Given this list of marker genes DMAP1, KCTD6, DENND6B, COQ10A, ZNF627, TANC1, LGALS9B, ANKRD13B, ESM1, IFT74, DLX2, RBMS2, KDM5B, TRMT1L (tRNA methyltransferase 1 like), CFAP97, NAB2 (NGFI-A binding protein 2), MAPRE3, LPP, BMI1, TUBB2A, SSH2, ATP8A1, CCS, BCKDHA, P2RX4, SPSB1, IFIT3, RIGI, C3orf33, PTGFRN, AHI1, FARSB, DNAH8, ARHGAP25, TP53INP1, SPOUT1, RREB1, CCDC126, LSM12, TNIP1, ATRAID, XAF1, IMMP2L, TNFSF11, RBM22, VCP, UBE3A, RING1, TNFSF8, ZCCHC12, MIGA1 (NCBI Gene Id 374986), DLG3, CUL9, ARHGAP39, PGS1, MARCKSL1, TESC, SCARNA13, HEXIM1, FAM168A, HIVEP2, RAC3, TFPI, RHOH, RPL30, SLC9A9, C19orf12, RCL1, CEP43, ARHGAP5, UBA7, C12orf57, COQ8A, GATAD2B, TRPM1, SCNM1, IFIT1B, LDOC1, CELA3B, RNF146, CYP4V2, CRPPA, LUZP1, PHF21A, CSTB, SLC46A3, GGPS1, PARP9, MANBAL, CSN3, GRHL1, TBC1D4, MFSD9, AGL, KSR1, GADD45B, WDFY2, OLFM2, MGST2, ZNF48, UBL5, PTPRE, PFKM, CLIP3, WDR43 (WD repeat domain 43), AICDA, GPAM, NTPCR, FAM120B, NRSN1, EXT1, CERS6, PNPO (pyridoxamine 5'-phosphate oxidase), LKAAEAR1, LIF, ANGPTL2, C19orf38, NPY4R, GTDC1, RASSF2, TOX2, TDRP, ADCK5, VCPIP1, D2HGDH, ATG10, RWDD3, AP3M2, SLC14A1, MX1, ZBTB4, LRIG1, TOR3A, EVI5, ZNF697, RSPH9, NARF, MATK (megakaryocyte-associated tyrosine kinase), ANKMY2, TRPC4AP (transient receptor potential cation channel subfamily C member 4 associated protein), DYNLT3, CHIA, CYTH3, AFP, LGR4, OAS2, ACP6, DYNLT2B, SMYD3, SUCLG1, CMC1, MPO, UTRN, DIS3L2, PTPN13, WNK3, ARID1B, FUNDC1, SLC30A8, MBNL2, CPN2, CCDC171, THNSL1, C8orf48, PHACTR2, NXPE3, SPOCK2, STX4 (NCBI Gene Id 6810), SLC46A1, SYNJ2, RPL19, RBM45, HEXA, LRRC28, EI24, TMEM86A, ITPR2, POLG, HSBP1, KIAA1549L, COLCA1 (colorectal cancer associated 1), CCDC28A, UBAC2, ADK, L3MBTL3, MRPL23, MAPK11, FAM171B, ZFP1, RYR1, DUSP6, DRC1, SLC26A2, LMNTD2, ABTB1, MRTFB, FLVCR2, ZNF878, SYT11, TSPAN32, here is a description of the gene set: Regulatory T (Treg) cells, whose identity and function are defined by the transcription factor Foxp3, are indispensable for immune homeostasis. It is unclear whether Foxp3 exerts its Treg lineage specification function through active modification of the chromatin landscape and establishment of new enhancers or by exploiting a pre-existing enhancer landscape. Analysis of the chromatin accessibility of Foxp3-bound enhancers in Treg and Foxp3-negative T cells showed that Foxp3 was bound overwhelmingly to pre-accessible enhancers occupied by its cofactors in precursor cells or a structurally related predecessor. Furthermore, the bulk of Foxp3-bound Treg cell enhancers inaccessible in Foxp3- CD4+ cells became accessible upon T cell receptor activation prior to Foxp3 expression with only a small subset associated with several functionally important genes being exclusively Treg cell-specific. Thus, in a late cellular differentiation process Foxp3 defines Treg cell functionality in an “opportunistic” manner by largely exploiting the preformed enhancer network instead of establishing a new enhancer landscape. from publication Samstein RM, Arvey A, Josefowicz SZ, Peng X, Reynolds A, Sandstrom R, Neph S, Sabo P, Kim JM, Liao W, Li MO, Leslie C, Stamatoyannopoulos JA, Rudensky AY (PMID 23021222) species: Homo sapiens Human Gene Set: GSE40685_NAIVE_CD4_TCELL_VS_TREG_DN Genes down-regulated in CD4: naïve versus FOXP3+ T reg.